Given this list of marker genes LAMB2, TNR, KIAA0319, PUM2, NTRK3, here is a description of the gene set: Human Gene Set: GOBP_SPROUTING_OF_INJURED_AXON The process involved in sprouting of an injured axon. studied in species Homo sapiens